The following is a description of a gene set: studied in species Homo sapiens Human Gene Set: GOBP_REGULATION_OF_AGGREPHAGY Any process that modulates the frequency, rate or extent of aggrephagy., and this is the list of marker genes: HDAC6, KAT5, BAG3, ZDHHC19, HTT, HSPB8, CSNK2A1 (NCBI Gene Id 1457), LYPLA1